Given this list of marker genes PLPP3, PDGFRA (NCBI Gene Id 5156), RAB31, CNP, OLIG1, SPARC, SCD5, PMP2, BCHE, LRRC4C, SPATA6, SEMA5A (semaphorin 5A), APOD, COL9A1, MMP2, DUSP6, NKX2-2, SPRY4, BCAN, LHFPL3, CD63, ITM2C, NXPH1, TRIB2, TSC22D4, SERPINE2, SLITRK2, ETV5, VXN, EPB41L2, PLLP (NCBI Gene Id 51090), EPN2, RAMP1, PDE4B (phosphodiesterase 4B), SOX10, PTN, CD9, PTPRZ1, GPR17, TSPAN7, LUZP2, SIRT2, PSAT1, ARC, C2orf80, SOX8, SLC35F1, PLEKHB1, GRID2, B2M, CSPG5, MT3, GPM6B, GATM, SCN1A, FIBIN, EDNRB, LSAMP, DBI, PLAT, OMG, NOVA1, RFTN2, CNTN1, NKAIN4, TTYH1, ITGB8, ARL4A (ADP ribosylation factor like GTPase 4A), COL20A1, CD82, KANK1, CADM2, ALCAM, SCRG1 (stimulator of chondrogenesis 1), SEZ6L, CST3, ANGPTL2, ANXA5, S100B, PON2, OLIG2, BRINP3, SOX6, GNG7, ETV1, SPRY1, LMF1, RHOC, LIMA1, CA10, PCDH15, here is a description of the gene set: studied in species Homo sapiens Human Gene Set: ZHONG_PFC_MAJOR_TYPES_OPC from publication Zhong S, Zhang S, Fan X, Wu Q, Yan L, Dong J, Zhang H, Li L, Sun L, Pan N, Xu X, Tang F, Zhang J, Qiao J, Wang X (PMID 29539641)